The following is a description of a gene set: species: Mus musculus from publication Chen Y, Wang X (PMID 31504780) Mouse Gene Set: MIR_12199_3P Genes predicted to be targets of miRBase v22 microRNA mmu_miR_12199_3p in miRDB v6.0 with MirTarget v4 prediction scores > 80 (high confidence targets)., and this is the list of marker genes: Zfp97, Antxr1, Nr3c1, Taf3, Btbd2, Tnrc6b, Man1a, Borcs8, Zfp65, Csgalnact2, Gabrg2, Tiparp, Kmt2e, Ppp4r1, Zfp738, Srsf11, Oprl1, Cdkl2, Rfx3, Arrdc3, Palb2, Ezh2, Esco1, Wdr26, Arl2bp, Mc2r, Rb1cc1 (NCBI Gene Id 77109), Gmps, Nampt (NCBI Gene Id 68683), Cand1, Scube2, Olig3, Slfn14 (schlafen 14), Omg, Afap1, Stx8, Bsph1, Lmo7, Sox21, Traf3 (NCBI Gene Id 22031), Igf1r, Usp14, Sash3 (NCBI Gene Id 74131), Osbpl8, Nsd3, Gulp1, P2rx2, Spdya, Aff2, Mindy2, St13, Stard13, Ppp1r15b, Rragc, Etnk1, Cntn4, Gpr137c, Slc30a7, Otud7b, Zfp960, Nkapl, Onecut2, Zfp729a, Prkag2, Grm1, Dcc, Sat1, Dip2b, Gpr12